Given this list of marker genes Mfn2, Runx1, Insl3 (insulin-like 3), Dmrt1, Nr5a1, Wt1, Retn, Gdf9, Nupr1, Sema3a, Insr, Sox9, Eif2s3y, Zfpm2, Dhx37, Cited2, Sry, Wnt4, Asmt, here is a description of the gene set: Mouse Gene Set: GOBP_REGULATION_OF_GONAD_DEVELOPMENT studied in species Mus musculus Any process that modulates the frequency, rate or extent of gonad development.